The following is a description of a gene set: studied in species Homo sapiens Human Gene Set: HP_TOE_SYNDACTYLY Webbing or fusion of the toes, involving soft parts only or including bone structure. Bony fusions are referred to as \bony\ Syndactyly if the fusion occurs in a radio-ulnar axis. Fusions of bones of the toes in a proximo-distal axis are referred to as \Symphalangism\. Toe syndactyly, and this is the list of marker genes: DLL4, NSD1, PSAT1, PALB2, MEIS2, APC, UBE2T, CPLANE1, SLC12A6, NECTIN4, FAT4, GNA11, FANCE, NEK9, TBX22, CKAP2L, SHH, NXN, PHIP, NECTIN1, FANCC, SCARF2, KMT2B, MAP3K20, HEPHL1, KCNJ5, FREM2, DYNC2H1, EN1, EBF3 (EBF transcription factor 3), RAD21, BMP4 (NCBI Gene Id 652), FIG4, IQSEC2, LMBR1, FLNA, FLII, GJA1, GDF5, ITGB4, SMAD2, MEGF8, CD96 (CD96 molecule), EBP, CUL4B, TBR1, RAI1, FRAS1, CSGALNACT1, TTC21B, SOX5, CERT1, SHANK3, SMO, IRF6, IL11RA, FANCM, RAD51C, FBXO11, ARHGAP31, H4C9, PDE6D, LIG4 (NCBI Gene Id 3981), CREBBP, FGF16, ITPR1, ZMIZ1, PIGY, ESCO2, TP63, ARL6IP6, BRD4, MEF2C, UBE2A, CTCF, ERCC4, FLI1, MAD2L2, RAB23, ADNP, CAMTA1, BCOR, WDR19, TMEM231, CNOT2, SHMT2, CACNA1C, ARMC9, MIR17HG, TELO2, GNE (glucosamine (UDP-N-acetyl)-2-epimerase/N-acetylmannosamine kinase), EP300, PUF60, MYRF, WNT7A, RBPJ, BMS1, NR4A2, SETD5, CEP55, POLR3A, SMARCAD1, KMT2A, BRCA1, MCTP2, AP1G1, TRIO, POLR3GL, TAF6, FANCG, RPL10, TRMT5, SLC12A2, FBLN1, GPC4, NSDHL (NCBI Gene Id 50814), EFNB1, FANCI, CRKL, GPC3, PLAAT3, XRCC2, DYNC2I2, TBX15, BCR, RBBP8, ROR2, DYRK1A, MAPRE2 (NCBI Gene Id 51683), MRPS28, SVBP, HDAC4 (NCBI Gene Id 9759), FGF10, ALDH1A2, CNTNAP1, WDPCP, TFAP2B, SMAD4, NBN, TBCK, MECP2, HOXD13, TWIST2, ARCN1, FANCA (NCBI Gene Id 82952), BHLHA9, RIPK4, RFWD3, PORCN, SMC1A, BBS7, WNT10B, ZNF699, TTI2, SCNM1, DEAF1, PRKD1, B3GLCT, MAPK1, MAB21L2, FGF9, KIF7, GRIP1, ATP9A (ATPase phospholipid transporting 9A (putative)), SALL1, CEP120, NEDD4L, TWIST1, OTUD6B, BRCA2, APC2, NOG, ATP6V1B2, IQCE, NIPBL, CDC45 (cell division cycle 45), SIN3A, FANCD2, STAG1, TXNL4A, DYNC2I1, CCNQ, IFT80, SYT1, SC5D (sterol-C5-desaturase), NSUN2, IFT140, PLEC, MAN1B1, DDX6, KDM5A, GABRA3, FANCL, FGFR1 (fibroblast growth factor receptor 1), SATB1, BMP2, MYH8, MYCN, SLX4, DYNC2LI1, H3-3A, CLCF1, BRIP1, IFT172, LRP4, KCNJ2, TAF4, RALA, PIK3CA, SF3B4, TRRAP, JARID2, FANCB, GLI3, DACT1, SMOC1, MED25, SIK3 (NCBI Gene Id 80236), DDX11, KIAA0753, PUM1, DHCR7 (7-dehydrocholesterol reductase), PHGDH, TCTN3, UBA2, HDAC8, FBXW11, IFT43, SALL4, CDH3, FDFT1, SMC3, KCTD1, FGFR3, WLS, FANCF, RHOA, FGFR2, RAD51, BMPR1B, SLC39A8